Given this list of marker genes Ulk2, Il15ra, Lrp1, Syngap1 (synaptic Ras GTPase activating protein 1 homolog (rat)), Lrrk2, Mbp, Wnt3a, Ngfr (nerve growth factor receptor (TNFR superfamily, member 16)), Dguok, Inpp5f, Crmp1, Spart, Pafah1b1, Ptprs, Epha3, Ntm, Plxna3, Arhgap4, Pten, Cyth2, Rhoa, Thy1, Cd38, Map4k4, Sema3a, Diaph2, Rtn4r, Gfap, Fat3, Nr2f1, Lrp4, Nlgn3, B2m, Amigo3, Spock1, Nrp1 (neuropilin 1), Sema5a, Trim46, Fgf13, Cdkl3, Efnb2, Dennd5a, Mag, Ulk1, Trpv4, Sema3f, Xylt1, Tsc2, Cbfa2t2, Dpysl3 (NCBI Gene Id 22240), Arf6, Rtn4rl1, Dleu2 (NCBI Gene Id 84093), Rgma, Minar1, Ephb2, Acp4, Adam17, Dip2b, Ube3a, Gsk3b, Rnf6, Paqr3, H2-K1, Draxin, Dync1i2, Ttc3, Gdi1, Cers2, Cdk5, Tsc1, Dab2, Inppl1, Lgals1, Epha7, Stx1b, Mt3, Ptpn1, Rap1gap2, Diaph1, Rab29, Nlgn1 (neuroligin 1), Ptprz1, Prkcsh, Fkbp4, Zfp296 (zinc finger protein 296), Hes1, Neu4, Efemp1, Wnt5a, Inpp5j, H2-D1, Flna, Thoc2, Ngef, Tnr, Tsku, Pmp22, Ntn1, Lpar1, Tbx6, Dab1, Ifrd1, Mdm2, Kremen1, D130043K22Rik, Runx1t1, Kank1 (KN motif and ankyrin repeat domains 1), Actr3 (NCBI Gene Id 74117), Zfp365, Bag5, Ptprg (protein tyrosine phosphatase receptor type G), Mgarp (mitochondria localized glutamic acid rich protein), Gak, Ryk, Stmn2, Sema3g, Cspg4, Vim, Cdh1, Rtn4, Rit2, Neo1, Rtca, Hdac6, Wnt3, Rtn4rl2, Sema6d, Hdac2, Slit2, Ccr5, Ptk2, Ptpn9, Lrig2, Dtnbp1, Dnm3, Map2, Sema6c, Apoe, Psen1, Dkk1, Rufy3, Itm2c, Prag1, Snapin, Efnb3, Slit1, Katna1, Epha4 (Eph receptor A4), Efna1, Gfi1, Adcy6, Mylip (myosin regulatory light chain interacting protein), Bcl11a, Gsk3a, Fstl4, Sema4f, Carm1, Trak2, Cib1, here is a description of the gene set: Mouse Gene Set: GOBP_NEGATIVE_REGULATION_OF_NEURON_PROJECTION_DEVELOPMENT species: Mus musculus Any process that decreases the rate, frequency or extent of neuron projection development. Neuron projection development is the process whose specific outcome is the progression of a neuron projection over time, from its formation to the mature structure. A neuron projection is any process extending from a neural cell, such as axons or dendrites (collectively called neurites).